Given this list of marker genes Cyp2b23, Cyp1a1, Cyp2b19, Cyp19a1, Cyp1a2, Cyp2b13, Cyp3a13, Cyp3a59 (NCBI Gene Id 100044462), Cyp1b1, Cyp2b10, Cyp3a25, Cyp2b9, here is a description of the gene set: species: Mus musculus Mouse Gene Set: GOMF_ESTROGEN_2_HYDROXYLASE_ACTIVITY Catalysis of the reaction: estrogen + reduced + O2 = 2-hydroxyestrogen + H+ + H2O + oxidized.